Given this list of marker genes PIK3CB, PLCD3, MTMR1, MTMR9, PIP4K2C, SBF2, MTMR10, PLCB4, PIP4K2B, PIK3CA, PIK3CG, PLCH2, SACM1L, PLCB1, PIP5K1B, PLCD4, PLCE1 (phospholipase C epsilon 1), MTM1, PIP5K1C, PLCB3, PIK3CD, PIK3C2G, MTMR6, MTMR8, PIP5K1A, OCRL, PIK3C2A, PLCZ1, PIP4P2, MTMR7, PLCH1, MTMR4, PIK3C2B, PLCB2, MTMR11, PIKFYVE, PIK3R4, PTEN, PIK3C3, MTMR3, MTMR12, MTMR2, PLCG1, PLCG2, PLCD1, PIP4P1, INPP5D, SBF1, PIP4K2A, here is a description of the gene set: Phosphoinositides metabolism Human Gene Set: WP_PHOSPHOINOSITIDES_METABOLISM species: Homo sapiens